Given this list of marker genes CNTN3, ATXN7L1, TMEM242, RRP12, TCF20, HLA-DOB, THSD7A, STAR, HPGD, CHSY1, BMP8B, ABCC4, CELSR2, OLA1, SLITRK2, VTCN1, BRWD3, CYP4F11, RBMXL3, OTUD3, ZC3H12C, BCL11B, SLC25A43, ADAMTS18, TSPYL6, CFAP97, FRAT1, SEPTIN11, OSBP2, RAVER1, ALG2, UEVLD, SNRNP25, VRK2, GTDC1, FHOD3, TMEM229A, A4GNT, INHBB, RAP1GAP2, LYSMD3, SH3BGRL2, DENND1B, DYNAP, BAAT, IL23A, STAU1, TBX15, ARHGEF33, CCL22, CD34, N4BP2L1, REPS2, here is a description of the gene set: from publication Chen Y, Wang X (PMID 31504780) studied in species Homo sapiens Human Gene Set: MIR4683 Genes predicted to be targets of miRBase v22 microRNA hsa-miR-4683 in miRDB v6.0 with MirTarget v4 prediction scores > 80 (high confidence targets).